The following is a description of a gene set: from publication Toker A, Engelbert D, Garg G, Polansky JK, Floess S, Miyao T, Baron U, Düber S, Geffers R, Giehr P, Schallenberg S, Kretschmer K, Olek S, Walter J, Weiss S, Hori S, Hamann A, Huehn J (PMID 23420886) We investigated at which stage of maturation commitment to a stable Foxp3-expressing phenotype takes place. We assessed stability of Foxp3 expression in thymic Foxp3+ Treg subsets of different maturity, defined by CD24 expression. Next we compared gene expression profiles of Foxp3+ Treg subsets (+) of different maturity (24lo, 24int, 24hi) and could identify a set of genes that were specifically up or downregulated in Foxp3+ Tregs, but not in Foxp3- conventional T cells, in a maturation-dependent manner. Human Gene Set: GSE42021_TCONV_PLN_VS_CD24LO_TCONV_THYMUS_UP species: Homo sapiens Genes up-regulated in T conv: peripheral lymph nodes versus thymic CD24 low., and this is the list of marker genes: KGD4, HOXA4, NR1H3, ATE1, TPM2, PCBD2, MS4A1, XPA, PARK7, SCGB1A1, ME1, TAP1, RETSAT, C8orf82, EBP (NCBI Gene Id 139151), SERPINB6, AGTRAP, WDR55, CLVS1, LSM14B, VPREB3, DLGAP4, LPCAT1, TRAF6, TBC1D14, RNF5, LAGE3, TAX1BP3, IFT25, ABHD14A, TUBA3C, HSPG2, PRR5, MCL1, JUP, GPR137B, TOMM7, ZFP28, IRF1, UBE2G1, WNT5B, FOXN1 (NCBI Gene Id 8456), SDHAF2, PIMREG, ADGRL1, RAX, NDUFS2, CUX1, SMTN, RFX2, FKBP5, DPYSL4, MRPL15, SMARCD2, RNF181, CETN1, CNIH2 (cornichon family AMPA receptor auxiliary protein 2), CUL1, RETN, TXNDC17, TBR1, NCOA3, CNTN1, DICER1, MPC2, MCEE, GYG1, AKT1, TMEM168 (NCBI Gene Id 64418), NDUFA12, NFIL3, EPHA3, PDE6B, HSD17B2, PADI3, TUBGCP3, MRAP, PTPRB, NEDD8, CTRB2, DDX4 (NCBI Gene Id 54514), PSMD12, SPAG7, REL, S100A5, C1orf52, MLYCD, DTD2, CRYBG1 (NCBI Gene Id 6763), TNFRSF4, MRPS21, CASP12, SLC38A10, PKP1, INTS5, MBTD1, COL9A3, RTCB (NCBI Gene Id 51493), GNB4, KRT12, TUFM, S100A4, CCNDBP1, TSPAN9, FAM216A, PITPNM1, PAPSS2, MRPL42, VSX2, CYFIP1, TSC22D1, CLIC4 (NCBI Gene Id 25932), CCNF, CCDC93, CRYAA, NDUFB3, DNAJB2, EXO1, TMCO1, INS, CEBPZOS, KRTAP13-2, KLK8, KIF2C, SPTSSA, ZNF688, TBRG1, CCDC117, HAGH, STS, ATRX, B3GALNT2, KRTAP19-5, ITPR2, SPINK4, PGLYRP1, ARHGEF1, GSTK1, MAP4, RFX1, TGFB2, TM4SF5, HASPIN, IVNS1ABP (influenza virus NS1A binding protein), SLC2A3, HLA-G, PDCD4, MARS1, FGF5, GNAI1, ZBTB22, RABEPK, CPSF4, MRPS15, SUDS3, YJU2, UBE2T, PURB, RAI2, HAS2, PPP2R5D, MAP3K11, RBM6, UQCRHL, AADAC, RBL2, TRAPPC12, CDKN1B, GCAT, H1-3, CDH11, ARF4, IGFALS, RNASEK, ARL3, MYCN, PODXL, HMCES, MYH6, SCP2, DNAJC13, KLHL7, SPA17, LAMA4, ACTN2, UBE3A, NTSR1, CNTFR, IFNB1, TRAF2, VPS45, ZFP62, ARIH1 (NCBI Gene Id 25820), SUPT6H, FIP1L1, CDC42SE1, SRPK3, FABP4, CNOT7, SLC37A4